Given this list of marker genes PDE6H, CACNA1F, TSGA10IP, RCVRN, CFAP410, ENKD1, MYRIP, TTLL6, PDE6G, PKHD1, WHRN, RHO, OPN5, GRK7, NPHP4, TULP1, GNGT1, RP1L1, NAPEPLD, OPN1MW3 (NCBI Gene Id 101060233), PPEF2, SDCCAG8, LYAR, PCDHB13, SPATA7, FAM161A (FAM161 centrosomal protein A), CNGB1, PIP4K2A, WDR19 (WD repeat domain 19), RGS9BP, MAGI2, CEP290, GNAQ, OCRL, LCA5, MERTK, NPHP1, TTC8, CEP250, CIB2 (calcium and integrin binding family member 2), IQCB1, PDE6A, SMO, GNB1, TULP3, DHRS3, ARR3, STX3, TMEM237, USH2A, CNGB3, CNGA1, CETN1, BBS4, PHLPP2, PDC, GUCA1ANB-GUCA1A, PRPH2, C1orf115, IFT52, OPN1LW, ROM1, OPN4, SAG, GUCA1B, CDHR1, CETN3, ABCA4 (NCBI Gene Id 7815), IFTAP (intraflagellar transport associated protein), SLC24A4, GUCY2F, ATP1A4, RD3, PHYH (phytanoyl-CoA 2-hydroxylase), MAP1B, IFT140, ARL3, IFT20, KIAA1549, IFT57, RPGRIP1, GRK1, SEPTIN2, GRK4, BSG, OPN1SW, TBCC, NXNL1, RPGR, PCDHB15, INHA, GUCA1C, PEX6, USH1G, RAB27A, GNA11, DYNLL2, USH1C, CFAP96 (NCBI Gene Id 441054), KIFAP3, PROM1, OPN1MW, GUCY2D, SPTBN5, CERKL, OPN1MW2, IFT80, RP1, EYS, TOPORS, MYO7A, GNAT1, CCDC66, BBS7, VCAN, TTLL4, PDE6B, KIF17, GUCA1A, CRB1, PRCD, IFT122, OPN3, PTGS1, SHANK2, RPGRIP1L, PCARE, POC5 (NCBI Gene Id 134359), CETN2, PCDH15 (protocadherin related 15), IMPG1, GNAT2, RAB37, MAK, here is a description of the gene set: A non-motile cilium where the axoneme has a ring of nine outer microtubule doublets but no central microtubules (and is therefore called a 9+0 axoneme). Human Gene Set: GOCC_9PLUS0_NON_MOTILE_CILIUM studied in species Homo sapiens